Given this list of marker genes RASAL1, HRAS, KRAS, NRAS, RASA4, RASA1, RASA3, RASA2, here is a description of the gene set: Human Gene Set: KEGG_MEDICUS_REFERENCE_REGULATION_OF_GF_RTK_RAS_ERK_SIGNALING_RASGAP Regulation of GF-RTK-RAS-ERK signaling, RasGAP. Pathway ID: N01600. Pathway type: Reference. Pathway class: nt06526 MAPK signaling. studied in species Homo sapiens Pathway Definition from KEGG: RasGAP -| RAS